Given this list of marker genes GNG11, GNB5, AQP11, GNB2, GNB4, ADCY9, PRKAR2A (protein kinase cAMP-dependent type II regulatory subunit alpha), ADCY1, AQP1, AVP, ADCY6, AQP2, PRKACB, AQP5, AQP6, AQP4, ADCY8, PRKAR2B, GNB1, PRKACA, ADCY4, ADCY2, PRKAR1B, GNAS, GNG13 (NCBI Gene Id 51764), GNGT2, GNG3, GNGT1, AQP12A, ADCY3, AQP3, GNG10, AQP7, GNG2, RAB11A, ADCY5, GNG7, AVPR2, PRKACG, GNG4, GNG12, PRKAR1A, RAB11FIP2, MYO5B, AQP10, GNG8, AQP8, AQP9, MIP, GNB3, GNG5, ADCY7, here is a description of the gene set: Human Gene Set: REACTOME_AQUAPORIN_MEDIATED_TRANSPORT species: Homo sapiens Aquaporin-mediated transport